Given this list of marker genes CBX1, RBM3, EIF4A2, RAB31, RPL12, KARS1 (NCBI Gene Id 3735), HNRNPA2B1 (heterogeneous nuclear ribonucleoprotein A2/B1), ETF1, RPS3, RNMT, PUM1, SLBP, SUCLG1 (NCBI Gene Id 8802), DHX30, EIF3F, ELOC, R3HDM1, SRSF9, FUBP1, RPL21, EEF1A2, NOLC1, RPS15A, EIF5, XRCC5, HNRNPA3P1, GTPBP6, EIF4B, EIF3I, SEPTIN2, RO60, FEN1, RPL22, RPL32, SNRPD1, SRSF10, PSMA1, RPL31, SNRPF, SFPQ, RRAGA (NCBI Gene Id 115960), U2AF1, SNRPD2, RPA1, RPL7A (ribosomal protein L7a), ACTL6A, RNASE4, RNASEH2A, TUBB4B, RPS8, RALA, RPS25, EEF1B2, RBMX, RIT1, RPS7, DDX39B, SF3A3, HNRNPH1, SRP9, RPS2, RPS10, NUP42, RPL29, RHOH, RBMS1, MSI1, EIF4EBP1, RPS23, EIF3H, POLR2G, ELOB, SEPTIN6, RAB10, HNRNPF, RPS28, RPS6, RPS19, YBX1, CIRBP, TUBB3, RAB14, RPL35, SRSF2, APEX1, EEF1A1, EFTUD2, EIF3D, GNAS, RPL38, RPS20, SRSF6, MBD4, KHDRBS1, IGF2BP3, RPL3, GEM, DFFA (DNA fragmentation factor subunit alpha), XRCC6, RPL15, EIF2S1, CBX4, RPL19, EIF4A1, CELF2, RPL18, GNA12, RBM5, RPS27, FBL, RAP1B, RAB2A, SNRPN, SSBP1, RPS11, TMPO, RALB, ZC3H11A, SNU13, RPP38, EIF3J, AIMP1, SNRPA, EIF4H, ZFP36, RBM4, RPS4Y1, SNRPC, RHOA, RPL37, EIF5A, HNRNPH2, EIF3G (eukaryotic translation initiation factor 3 subunit G), RAD23A, EIF3E, SRSF7, CHD4, MRPL23, RPL6, PCBP1, SRSF11, NUDT1, RPL8, DDX3Y, RPL9, SSB, PABPC4, RPS15, FMR1, PABPC1, RPA3, EIF6, RPL11, MRPL3, SNRPG, CARS1, EIF4A3, SNRPD3, PCBP2, RNASET2, RPL7, RAB11A, RPS13, RAB13, RPS12, SF3A1, SUB1, EWSR1, CSTF2, CHAF1A, GNL2, HNRNPR, NCL, HNRNPC, EIF4G2, EIF3C, POLA1, RAB5C, AARS1, GSPT1, RPS4X, SNRPE, HNRNPL, TUBA3C, EIF4EBP2, EEF2, HNRNPA1, RPS17, HNRNPUL1, SMARCC1, RAN (RAN, member RAS oncogene family), HNRNPA0, RPL23A, HMGB1 (high mobility group box 1), SRP14, TIAL1, FUS (NCBI Gene Id 406232), EEF1D, SNRPA1, TUFM, NCBP2, RTCA, SATB1, RPLP0, ARF5, RPL18A, RPL27A, SCG5, RPS24, ILF2, CBX6, MRPL12, NARS1, RPL26, TRA2B, RPLP2, LSM1, ARF4 (ADP ribosylation factor 4), SRP19, GNAI2, EIF2S3, OAS1, SFSWAP, EEF1G, RPS16, TUBA4A, YBX3, RPL24, BZW1, RPN1, EIF1, RPL17, SRP54, RAB5A, RPLP1, SLU7, SNRPB2, ARFIP2, RPS29, NPM1, HDLBP, here is a description of the gene set: Genes in the cancer module 32. studied in species Homo sapiens Human Gene Set: MODULE_32